Given this list of marker genes TOX, HMGB3 (high mobility group box 3), CENPE, CHD3 (NCBI Gene Id 1107), HMGB2, CENPA, MAP2, CENPF, H2BC12, H2AC6 (NCBI Gene Id 8334), CBX1, TERF2, H2AC8, H2AC18, H1-2, H2BC13, H2BC21, H2BC11, H2AZ1, MAP7, H1-0, H2AX, here is a description of the gene set: studied in species Homo sapiens Genes in the cancer module 168. Human Gene Set: MODULE_168